The following is a description of a gene set: Any process that stops, prevents or reduces the frequency, rate or extent of cellular senescence. species: Homo sapiens Human Gene Set: GOBP_NEGATIVE_REGULATION_OF_CELLULAR_SENESCENCE, and this is the list of marker genes: TWIST1, TBX2, HMGA2, TERC, FZR1, MIR543, AKT3, MIR590, PTEN, FBXO5 (F-box protein 5), TP63, ABL1, SIRT1, SIRT6, WNT1 (NCBI Gene Id 7471), BCL2L12, PLK2, YBX1, MIR17, BCL6, RBL1, TERF2, MIF, CDK6 (cyclin dependent kinase 6), TERT, ZKSCAN3